Given this list of marker genes Dnajb1, Aprt, Polr1d, Supt4a, Mcm5, Csrp1, Ier2, Hmox1, Ppa1, Ran, Srm, Ptpn14, Pnp, Snora33, Smad2, Rac1, Lig1, Cdk7, Il1rn, Hmgb2, Rack1, Pcna, Actg1, Gtf2f1, Eed, Sms, Cdk2, Ifrd1, Pabpc4, Pcsk7, Mcm2, Hspa8, Hsph1, Mcm4, Acly, Mcm6, Rrm1 (NCBI Gene Id 20133, ribonucleotide reductase M1), Krt19, Gh, Eif4e2, Pdcd2, Eef1b2, Ngf, Fen1, H2az1, Pick1, Stam, Rbbp7, Zfp607a, Rpsa, Csn3, Atp6v1c1, Ccne1, Nelfe, Ywhah, Tyms, Adm, here is a description of the gene set: Nitric oxide (NO) can modulate numerous genes directly; however, some genes may be modulated only in the presence of the inflammatory stimuli that increase the expression of the inducible nitric oxide synthase (iNOS). One method by which to examine changes in NO-mediated gene expression is to carry out a gene array analysis on NO-nai;ve cells. Herein, we report a gene array analysis on mRNA from iNOS-null (iNOS(-/-)) mouse hepatocytes harvested from mice exposed to NO by infection with an adenovirus expressing human iNOS (Ad-iNOS). Of the genes on this array, only approximately 200 were modulated either up or down by the increased iNOS activity according to our criteria for significance. Several clearly defined families of genes were modulated, including genes coding for proinflammatory transcription factors, cytokines, cytokine receptors, proteins associated with cell proliferation and cellular energetics, as well as proteins involved in apoptosis. Our results suggest that iNOS has a generally anti-inflammatory and anti-apoptotic role in hepatocytes but also acts to suppress proliferation and protein synthesis. The expression of iNOS results in increased expression of stress-related proteins, including heme oxygenase-1 (HO-1). We used HO-1 to confirm that a significant change identified by an analysis could be demonstrated as significant in cells and tissues. The elevation of HO-1 was confirmed at the protein level in hepatocytes in vitro. Furthermore, iNOS(-/-) mice experienced greatly increased liver injury subsequent to intestinal ischemia/reperfusion injury, associated with an inability to upregulate HO-1. This is the first study to address the global gene changes induced by iNOS in any cell type, and the findings presented herein may have clinical relevance for conditions such as septic or hemorrhagic shock in which hepatocytes, NO, and HO-1 play a crucial role. Up-regulated in hepatocytes upon expression of NOS2. from publication Zamora R, Vodovotz Y, Aulak KS, Kim PK, Kane JM 3rd, Alarcon L, Stuehr DJ, Billiar TR (PMID 12381414) Mouse Gene Set: ZAMORA_NOS2_TARGETS_UP species: Mus musculus